Given this list of marker genes SORT1, CUBN, CLTC, LRP2, DNM2, AP1S3, TFRC, AP2S1 (adaptor related protein complex 2 subunit sigma 1), SNAP91, TF, ARRB2, HIP1R, VLDLR, RAMP2, AP1S2, SPHK1, SH3BP4, AP2A1, FCHO2, SGIP1, CLTCL1, FCHO1, MYO6, CTTN, LRP1, NECAP1, CCDC32, AP2B1, DNM1, HSPD1, FNBP1, APP, TBC1D5, EPN3, REPS1, SNX9, CEMIP, EPS15L1, ARRB1, AP2A2, AP1S1, NUMB, LRP10 (NCBI Gene Id 26020), FCHSD2, CLTA, BTBD8, STON1, LRP12, GAS7, AMN, STON2, SLC18A3, AAK1, ATAT1, LDLR, DNM1L (NCBI Gene Id 692222), SELE, OCRL, EPS15, CDHR5, INPP5F (NCBI Gene Id 22876), RAB35, ADCY8, ACKR3, ITSN1, EPN1, NECAP2, PICALM, BMPR2, DGKD, TNK2, SYNJ1, CLTB, AP2M1, AP1G1, LRP3, DAB2, SLC2A4, here is a description of the gene set: A part of the endomembrane system in the form of an invagination of a membrane upon which a clathrin coat forms, and that can be converted by vesicle budding into a clathrin-coated vesicle. Coated pits form on the plasma membrane, where they are involved in receptor-mediated selective transport of many proteins and other macromolecules across the cell membrane, in the trans-Golgi network, and on some endosomes. studied in species Homo sapiens Human Gene Set: GOCC_CLATHRIN_COATED_PIT